Given this list of marker genes PRKACA, GRK6, AREG, CGA, CREB1, FSHB, EIF4EBP1 (NCBI Gene Id 1978), CYP19A1, MAPK1, BDNF, MTOR (mechanistic target of rapamycin kinase), PRKCA, RPS6KB2, SGK1, TSC2, FOXO1, H3-4, SRC, APPL1 (adaptor protein, phosphotyrosine interacting with PH domain and leucine zipper 1), RPS6, RHEB, FSHR, MAPK14, MAPK3, AKT1, RAF1 (Raf-1 proto-oncogene, serine/threonine kinase), RPS6KB1, here is a description of the gene set: Follicle stimulating hormone (FSH) signaling Human Gene Set: WP_FOLLICLE_STIMULATING_HORMONE_FSH_SIGNALING species: Homo sapiens